The following is a description of a gene set: part of: The phototransduction cascade Reactome Pathway: Activation of the phototransduction cascade This event has been computationally inferred from an event that has been demonstrated in another species.<p>The inference is based on the homology mapping from PANTHER. Briefly, reactions for which all involved PhysicalEntities (in input, output and catalyst) have a mapped orthologue/paralogue (for complexes at least 75% of components must have a mapping) are inferred to the other species. electronically inferred by orthology from the curated human pathway studied in species Mus musculus, and this is the list of marker genes: Pde6b, Rho (rhodopsin), Gnat1, Cngb1, Cnga1 (NCBI Gene Id 12788), Pde6g, Gngt1